The following is a description of a gene set: studied in species Homo sapiens Reactome Pathway: Developmental Cell Lineages of the Integumentary System <p>The integumentary system consists of skin, the largest organ of the body that serves as a barrier from the outside world, and its adnexal structures, such as hair, nails, sebaceous, apocrine, and mammary glands (Sundberg et al. "Skin and Adnexa", pp. 511-542).</p><p>Epidermis is the outermost skin layer, facing the outside environment, and consists of stratified squamous epithelial cells called keratinocytes (Sundberg et al. "Skin and Adnexa", pp. 511-542).</p><p>Mammary glands are modified apocrine (sweat) glands that secrete milk, the primary food source of newborn mammals (Sundberg et al. "Skin and Adnexa", pp. 511-542).</p> part of: Developmental Cell Lineages, and this is the list of marker genes: TGFA, EGF, FGF10, PRL, AREG